Given this list of marker genes FES, TMED10, FGG, FBXO45 (NCBI Gene Id 414772), RIMS2, SRCIN1, SYT8, IL13RA2, FCGR2B (NCBI Gene Id 2213), SACM1L, CD177, SYT5, HCK, RIMS4, ITGAM, KCNB1, CHGA, EXOC2, PRSS12, TSG101, CBL, CLNK, WASHC1, UNC13A, CORO1A, LAT2, SNAP25, SNCA, LIN7B, RAB27A, RAB26, CFTR, EFR3A, TMEM63B, CCL5, FCER1G, ARHGAP44, ADORA2B, SYTL2, STAM, RABEPK, GIT1, EQTN, EXPH5, RAB7A, RAB10, CHMP3 (NCBI Gene Id 51652), RAB21, PDCD6IP, SNX4, ABCA12, VTI1B, CCL3, SNX6, ATP2A2 (NCBI Gene Id 488), CCR2, ITSN1, RAB3D, CD300A, DNAJC5, SPHK2, HAP1 (huntingtin associated protein 1), PTGDR, NCKAP1L, MIA3, P2RX7, EXOC1, ADRA2A, ANXA2, FCGR3A, SCRIB, FGB, SYT1, MRGPRX2, RAB12, NR4A3, STX17 (syntaxin 17), RAP1BL, IL13, STX4, CSPG5, REST, SYNGR3, ERC2, LAMP1, ADGRE2, RAB11FIP5, RAP1B, ANK1, PRKCG, SYP, SNPH, TNFAIP2, CHMP2A, RPH3A, LRRK2, CEACAM1, CPLX2, NSF, RAB8A, EXOC6B, CLASP1, EXOC3, PAK1, RAB8B, VAMP7, SYTL4, SYT17, STX2, RAB44 (RAB44, member RAS oncogene family), APOLD1, SNF8, SLC4A8, TRARG1, CD84, EXOC4, RAB11FIP1, RAB3C, CACNB4, SYTL5, TPCN2, PSEN1, IL4R, SYT4, SYT2, MYO1G, PPP3CA, SNX19, SDC1, HGS, GNAI2, UNC13D, SNAP47, ATP13A2, P2RY1, SYT3, LIN7A, RALA, FCER1A, TMEM79, TXLNA, STXBP1, SCIN, EXOC3L4, SDCBP, SYT15, ARFGEF1, RAB25, STEAP2, RAB9A, SYT10, GRIK5, WASHC3, WASH6P, LLGL1, FGR, SPI1, BRSK1, SV2C, P2RX1, CDK5R2, WIPF3, HLA-F, MICAL3, SNAP23, SCAMP5, PRKCA, RAB31, RAB13, ABCC4, FMR1, RAB11B, RASGRP1, SYK, STXBP3, EXOC3L1, WDR41, LIN7C, PRKCB, CLTRN, CBARP, PLEK, RAC2, VAMP3, SYT7, SEPTIN5, VPS4A, SCAMP1, RAB11FIP2, RAB2B, SYNGR1, RAB3A, LAT, EXOC3L2, CDK16, PPFIA3, CDK5, CPLANE2, GPR151, CACNA1B, VAMP2, STX11, RAB27B, GATA1 (NCBI Gene Id 2623), UNC13B, SYT13, CCR1, PREPL, DTNBP1, STX1A, BRAF, LGALS9, BLOC1S6, VPS11, WNT7A (Wnt family member 7A), RAP1A, SCRN1, GNAO1, GATA2, NLRP5, GAB2, ZP4, OTOF, SEPTIN4, FOXF1 (forkhead box F1), GRXCR1, CD160, PDPK1, RAB40A, SMCR8, SDF4, VAMP8, CALM3, GRP, AP1G1, F2RL1, RIMS1, EXOC8, TPRG1L, SNAPIN, STXBP5, STX1B, KIT, RAB5A, RAB40B, SYN1, CPLX4, LYN, RPH3AL, KLRF2, SYT6, VPS4B, RAB11A, PIK3CD, CRHBP, COPS5, KLRC2, CLASP2 (cytoplasmic linker associated protein 2), RAB3GAP1, DOC2B, SNAP29, ARL8B, UNC13C, C9orf72, MYH9, CHMP6, BCR, SYTL3, PRAM1, EXOC7, SCN11A, PRRT2, TMEM167B, IL1RAPL1 (interleukin 1 receptor accessory protein like 1), JAGN1, TRIM72, STX3, CADPS2, RIMS3, NKD2, PIP5K1C, SYNGR2, NAPA, LGI3, GPR15LG, SYCN, PPFIA2, STXBP2, ARFGEF2, PLA2G3, TPH1, SYTL1, BAIAP3, CADPS, PPP3CB, EXOC5, SYN2, STXBP5L, FGA, RABGEF1, FBXL20, PTGDS, SYT11, KCNQ3, VSNL1, ANXA1, SEPTIN1, IGHE, PRKN, CPLX3, NAPB (NSF attachment protein beta), CASK, OSBPL2, RAPGEF4, RAB40AL, SYT12, TRAPPC11, TRPV6, SMPD3, ANXA3, SLC18A2, IFNG, PCLO (piccolo presynaptic cytomatrix protein), SYNJ1, RAB15, RAB40C, TSPAN18, ZP3, SV2B, NLGN1, BTK, RAB37, SYT9, MYH10 (myosin heavy chain 10), CPLX1, LLGL2, RAB33B, FERRY3, MILR1, STX19, MICAL1, ITGB2, NPY, DVL1, SDC4, RAB3B, WASH3P, DOC2A, HYAL3, EXOC6 (exocyst complex component 6), VPS18, STXBP6, S100A13, TMEM167A, BRSK2 (NCBI Gene Id 9024, BR serine/threonine kinase 2), ATP9A, RUFY4, S100A10, PFN2, NKG7, CCL8, PIK3C2A, PIK3CG, RALB, NOTCH1, SV2A, YKT6, here is a description of the gene set: Human Gene Set: GOBP_EXOCYTOSIS species: Homo sapiens A process of secretion by a cell that results in the release of intracellular molecules (e.g. hormones, matrix proteins) contained within a membrane-bounded vesicle. Exocytosis can occur either by full fusion, when the vesicle collapses into the plasma membrane, or by a kiss-and-run mechanism that involves the formation of a transient contact, a pore, between a granule (for example of chromaffin cells) and the plasma membrane. The latter process most of the time leads to only partial secretion of the granule content. Exocytosis begins with steps that prepare vesicles for fusion with the membrane (tethering and docking) and ends when molecules are secreted from the cell.